Given this list of marker genes Tnrc6b, Tob1 (NCBI Gene Id 22057), Cnot7, Btg2 (NCBI Gene Id 98237), Tnrc6a (NCBI Gene Id 76695), Polr2g, Cnot1, Pabpc1, Tent4b, Tnrc6c, Eif4enif1, Tent4a (NCBI Gene Id 210106), Zfp36, Ago2, Cpeb3, here is a description of the gene set: Any process that modulates the frequency, rate or extent of poly(A) tail shortening of a nuclear-transcribed mRNA. Poly(A) tail shortening is the decrease in length of the poly(A) tail of an mRNA from full length to an oligo(A) length. studied in species Mus musculus Mouse Gene Set: GOBP_REGULATION_OF_NUCLEAR_TRANSCRIBED_MRNA_POLY_A_TAIL_SHORTENING